Given this list of marker genes ILDR2, NCK2, AIRE, SLAMF8, MPL, TCIRG1, MIF, TNFSF4, SLC4A2, SOS1, TWSG1, PKNOX1 (PBX/knotted 1 homeobox 1), BTN2A2, RAB29, CD320, PTK2B, CLEC4D, JAK1, ITGB1, THEMIS, TRBC2, DUSP3, SP3, EFNB3, JAML, RUNX1, CD37, GPR89A, MIR30B, ADAM8 (ADAM metallopeptidase domain 8), NFAM1, KLRC1, TRBC1, CHRNB2, CD81, SAMSN1, TAC1, STAT5A (NCBI Gene Id 6776), KDELR1, CLNK, SNX27, CUL4A, PRLR, THEMIS2 (NCBI Gene Id 9473), PLCL2, ANXA1, CD44, CCR6, MIR181C, TNFSF13, RAC2, IFNA10, CD3E, KIT, NLRC3, ACTL6B, IRF2BP2, SOCS5, VSIG4, CLEC12A, IL1RL2, SPI1, ITCH (itchy E3 ubiquitin protein ligase), CCL5, NBN, GLI3, TNFRSF9, PREX1, IL4R, LEF1, WAS, FBXO7, ADORA2A, SCGB1A1, EPO, CD86, LAG3, PLCG2 (phospholipase C gamma 2), PELI1, SPINK5, ACTL6A, CDH26, OPA1, DNAJA3, BID, HLA-E, TUSC2, IMPDH1, FCRL3, APBB1IP, PCK1, IL7R, TNFSF14, DNAJB9, TPD52, MICB, MNDA, ULBP3, CD274, AHR, DOCK8, ERCC1, CLEC4A, HLA-DOB, ALKBH5 (alkB homolog 5, RNA demethylase), GRB2, ZFP36L1, SMAD7, SIRPB1, SH3RF1, PRDX2, NCK1, NCAPH2, IFNB1, BST1, SIRPA, TNIP2, CEBPB, HLA-F, RIPOR2, SFRP1 (secreted frizzled related protein 1), IL6, ARID1B, BTNL2, FCRL1, SLAMF7 (SLAM family member 7), BAK1, IL6R, CTSL, LOXL3, TRDC, MICA, PAX5, SKAP2, HSPD1, RORA, USP44, IL11, STAT5B, TESPA1, BLOC1S6, HLA-DPB1, IL2, SPTA1 (NCBI Gene Id 6708), PPP3CA (NCBI Gene Id 5530), SFTPD, BCL6, MZB1, IL20RB, KLRC4-KLRK1, ICOSLG, DCLRE1C, SLC39A7, HLA-DRB3, NOTCH2, KCNK18, SMARCC1 (NCBI Gene Id 6599), PGLYRP3, CR2, VNN1, HLA-DQA1, EGR3, MAP3K8, PBRM1, HSPH1, EPHB2, PIK3CD, RPL22, ZBTB7A, F2RL1, BCL10, PLA2G2D, IRF8, MR1, CD74, TCF7, IFNA5, SHLD2, KIF13B (kinesin family member 13B), JMJD6, MAPK8IP1, CXADR, CEACAM1, MMP14, CD276, KLRC2, NEDD9, VTCN1, ZAP70, TBX21, CXCR5, GLMN, MIR27A, SMARCC2, SANBR, SUPT6H, IL9, EGR1, CD70, TIRAP, SLAMF1, CAV1, IFNG, INS, B2M, STAT6, SOCS6, BST2, IL23R, TARM1, CD209 (NCBI Gene Id 30835), ADA, HPRT1, IL5, IL21R, PPP2R3C, VAV3, INHA, PLA2G5, PAG1, ARG2, AP1G1, GLI2, ITK, HSH2D, ICOS, IKZF3, SLA2, IL13, PRR7, CBLB, FZD5, PIBF1, NCSTN, ZBTB16, YES1, UNC13D, EMP2, CMTM7, RELB, EXO1, IMPDH2, FNIP1, TICAM1, CD47, MAD2L2, HLA-DRA, ATP7A, CYRIB, TXLNA, IL36B, ABL2, SRC, CD48, ASCL2, JUNB, PRKAA1, MARCHF7, LRRC32, CCR7, CBFB, SOD1, SYVN1, NOD2, TNFSF18, SLC25A5, LY9, ICAM1, RNF8, LGALS8, TYROBP, PKN1, SWAP70, P2RX7, RNF41, DOCK2, AMBRA1, HLA-DRB4, PRKCQ, CD22 (NCBI Gene Id 933), BMP4 (bone morphogenetic protein 4), BRD2, EBI3, SMARCD1, PHB2, BANK1, ULBP2, MSH2, KITLG, POU2AF1, TRGC1, GAS6, PIK3R3, AKT1, SOX11, IGF1, SLC46A2, MS4A1, FZD8, SYK (spleen associated tyrosine kinase), HDAC5, JAK3, IFNA14 (interferon alpha 14), CLEC7A, ZFP36L2, IKZF1, KAT5, PHF10, VCAM1 (vascular cell adhesion molecule 1), MALT1, FGL2, PNP, RAG2, IGF2, SHH (sonic hedgehog signaling molecule), KLRF1, CD300A, HAVCR2, NSD2, NFKBIZ, IDO1, PDCD1LG2, TRAF3IP2, HDAC4, PARP3 (poly(ADP-ribose) polymerase family member 3), CD244, SLC7A1, KMT2A, NKX2-3, DCAF15, LY6D, HLA-DMB, KMT5B, CCR9, LGALS9, HES1, CDKN1A, IL18R1, WNT1, METTL3 (methyltransferase 3, N6-adenosine-methyltransferase complex catalytic subunit), SOS2, GNRH1, HMGB3, TRAF2, SMARCE1, LGALS9C, CDK6, PDCD1, FBXO38, BCL11B, MLH1, CDH17, YWHAG, WNT4, IFNA1, DCAF12, LCK, SASH3, NCKAP1L, PRELID1, IFNA8, VAMP2, SCRIB, AP3D1, BTK, ZC3H12A, PSEN1, STOML2, TLR4, AKAP17A, RORC, ARID2, IL12RB1, PGLYRP1, LGALS1, SLC11A1, CLCF1 (cardiotrophin like cytokine factor 1), NEDD4, FANCD2, RHOH, CYP26B1, MAFB, MEN1, PSMB11, RASSF5, MAD1L1, PLA2G2A, FOXJ1, HLA-DRB1, TYRO3, KAT7, PURA, ZP4, NFKBID (NFKB inhibitor delta), CD4, PRKAR1A, RC3H1, PGLYRP2, PTPRJ, KLHL22, LMBR1L, PTPN2, STK11, PSG9, KLF6, HLA-DMA, ZP3, MDK, LAPTM5, TYK2, DOCK11, SOX12, NFATC2, SLAMF9, TCF3, ZNF683, AXL, TMIGD2, DCAF1, ONECUT1, CASP3, TREM2, HLA-DPA1, SLC39A10, FYN, XBP1, GPAM, MIR19A, FADD, IFNA16, NDFIP1, SH2D2A, TLR9, GPS2, IL1A, NFATC3, SH3KBP1, PRDX1, IL15, CD5 (NCBI Gene Id 921), FGF10, TSPAN32, PLA2G2F, TP53 (tumor protein p53), IRS2, CCL2, LYN, PMS2, SMARCD2, IL12A, HLA-DRB5, NFIL3, IL2RA, MSH6, TNFRSF14, RC3H2, EIF2AK4, LAX1, IL1B, IFNL1 (NCBI Gene Id 282618), ID2, RIPK2, CD3D, ZEB1, CD3G, FOSL2, PSMB10, ATF2, HDAC9, CD160, RAG1, CD69, SLAMF6, CCR2, SOX13, LILRB2, SMAD3, NHEJ1, NCR1, CLC, ITGAL, LCP1, IL7, CD1C, AIF1 (NCBI Gene Id 9471), XRCC6, CD46, RABL3, XCL1, RPS3, PTCRA, LEP, GPR183, KLRK1, CD55, BTN3A1, RUNX3, CD84, LIG4, TGFB1, PLXNA1, CASP8, KLRF2 (killer cell lectin like receptor F2), PRKCZ, PTPN22, CCND3, IGBP1, IL4I1, ERBB2, AICDA, TBK1, PRKCB, STAT4, CD79B, SMARCA2, TBC1D10C, SIT1, UNG, CD80, TREX1, HLA-DQB2, IL15RA, RHBDD3, TREML2, IGHE, FOXP3, ABL1, FZD9, TSC1, EFNB2, DDRGK1, FOXO3, BRD4, DAPL1, HLA-DQA2, MIR130A, GIT1, MYD88, CADM1, PIK3CG, MEF2C, CD151, NKAP, SMARCA4, IL10, PAWR, FLT3, JAK2, DDOST, BCL2, AGER, SPN, IL23A, MSN, HHLA2, CD7, KLRD1, RASGRP1, ACTB, SIRPG, FLOT2, GPR65, CD28, CD2, KIR3DS1, IFNA2, IFNA6, BTLA, ELF4, IHH, SMARCB1, BRD7, IFNA17, SRF, PIK3R2, MIR21, C17orf99, GPNMB, WDFY4, THY1, LAT2, MYB, MFNG, INPP5D, GAL, DUSP22 (dual specificity phosphatase 22), DTX1, PDP2, TRAC, TNFSF8, SH2D1A, RAB27A, MERTK, ATG5, SMARCD3, CD1D, PPP3CB, STAT3, PDPK1 (NCBI Gene Id 5170), ATM, IL27RA, UFL1, POLM, SOX4, CHRNA4, ULBP1, DLL4, PTPN6, MTOR, FKBP1B, HLA-A, TIGIT (NCBI Gene Id 201633), TOP2B, PTGER4, ZC3H8, CD24, IL6ST, FANCA, SLC15A4, AZI2, DLG1, HELLS, CLEC4G, CD40LG, CR1, PIK3R1, CD19, CD2AP, SHLD1, TNFRSF13C, KLRC3, MYH9, JAG2, YY1, PTPN11 (NCBI Gene Id 84990), RPL13A, CLEC2B, CCDC88B, AQP8, IGFBP2, SEMA4A (semaphorin 4A), ITPRIPL1 (ITPRIP like 1), CCL21, EOMES, FKBP1A, VAMP7, HLX, DPP4, CD6, IFNE, ITFG2, IL18, AP3B1, VAV1, CORO1A, DOCK10, ADGRG3, CD8A, TRAF6, IFNW1, RSAD2, LRRC8A, TFRC, CD247, ADAM10, TNFAIP3, FCHO1, FGR, PHB1, DLL1, DHPS, ARG1, PIK3R6, LEPR, CRACR2A, NRARP, C3, GAPT, FLT3LG, RNF168, ITPKB, IFNK, FCGR2B, CD8B, TNFRSF13B, SART1, TNFRSF4, AKIRIN2, SHLD3, CLPTM1, KLHL25, EXOSC3, CHD7, LIPA, GBA1, ENTPD7, LAT, IL21, LMO1, WNT3A (Wnt family member 3A, NCBI Gene Id 89780), SOCS1, BAX, TNFRSF1B, NCR3LG1, CCL19, SDC4, ZBTB1, IL27, MIR185, CEBPG, FOXN1, SEMA6D (semaphorin 6D), CSK, TP53BP1, ZNF335, EP300, IGHM, HMGB1, ADAM17, HLA-DQB1, ZBTB7B, PRDM1, LST1, PTPRC, IRF1, CDKN2A (cyclin dependent kinase inhibitor 2A), EPHB1 (EPH receptor B1), CLEC4E, FUT7, RASAL3, SLC39A6, DROSHA, DLG5, NKG7, ITGA4, ARID1A, NTRK1, RARA, CTLA4, CTNNB1, TNFSF9, PRKCD, GPR18, CD79A, RUNX2, PAXIP1, SOCS3, CEACAM21, PYCARD, RIPK3, PBX1, IFNA4, HLA-DOA, SELENOK, FCRL5, IFNA7, LILRB1, VSIR, LILRB4, RBPJ, ITM2A, HMCES, TGFBR2, CAMK4, NLRP3, CD27, TMEM131L, FOXP1, CD83, CD38, PHF14, GSN (gelsolin), TAOK3, CYLD, ATAD5, FGL1, BLOC1S3, EZH2, IL12B, CD40, KAT2A, PATZ1, BMI1, HLA-G, FZD7, LAMP1, DUSP10, BRAF, BLNK, BCL3, CGAS, NCR3, LGALS9B, BATF, NR5A2, WNT10B, BAD, CRTAM (NCBI Gene Id 56253), TACR1, TNFAIP8L2, FCER1G, MIR17HG, CARD11, CTSG, IFNA21, ZNHIT1, KMT5C, ZFPM1, ZMIZ1, EFNB1, RHOA, PRKDC, TNFSF11, ARMC5, TOX, IL4, RBX1, GATA3, TNFRSF21, HHEX, FCGR3A, LGALS3, LFNG, TMEM98, BAG6, APLF, CD180, PCYT1A, TNFSF13B, LYL1, SPIB, MYC, RIF1, IRF4, CTPS1, PRNP, PCID2, ST3GAL1, PRF1, SHB, CLECL1P, IL2RG, GPR89B, EXOSC6 (exosome component 6), INHBA, HFE, here is a description of the gene set: studied in species Homo sapiens Human Gene Set: GOBP_LYMPHOCYTE_ACTIVATION A change in morphology and behavior of a lymphocyte resulting from exposure to a specific antigen, mitogen, cytokine, chemokine, cellular ligand, or soluble factor.